The following is a description of a gene set: Human Gene Set: GSE39916_B_CELL_SPLEEN_VS_PLASMA_CELL_BONE_MARROW_DN Genes down-regulated in spleen B lymphocytes versus bone marrow plasma cells. from publication Benson MJ, Aijö T, Chang X, Gagnon J, Pape UJ, Anantharaman V, Aravind L, Pursiheimo JP, Oberdoerffer S, Liu XS, Lahesmaa R, Lähdesmäki H, Rao A (PMID 22991471) CD138+ B220- plasma cells were sorted from bone marrow and B220+ CD23+ mature follicular B cells were sorted from the spleens. Plasma cells were sorted from C57BL/6 mice 7 days after boosting with antigen, with mice first primed with an i.p. injection of KLH/IFA followed by boost at day 21 with KLH/PBS i.p. Mature B cells were sorted from antigen-naïve C57BL/6 mice. We compared expression profiles of plasma cells and mature B cells to identify differentially expressed transcripts. species: Homo sapiens, and this is the list of marker genes: SCN8A, TSPAN3, TPST2, SALL1, ITM2C, PLSCR1, RNASE4 (ribonuclease A family member 4), ABCB1, TRH, ORAI3, RBM47, ZDHHC2, HMGN3, ENPP1, ST3GAL6, BCL2A1, IL18RAP, FLOT1 (NCBI Gene Id 10211), RALGDS, CSF2RA, NR1D1, NRP1, ATXN1L, BAG3, MAPRE2, S100A6, PID1, OSBPL3, PARP16, CAMK2N2, MTHFS, EID2, GRN, RAPH1, GPM6B, SEMA7A, REPIN1, PTPN13, ID2, SP7, MEF2B, IFNAR2, PEAR1, S100A11, CD44, VMP1, ADORA2A, NUDT16L1, SLC26A11, KIF5C, ENDOD1, CDKN1A, NKG7, HACD3, GAA, CDK5R1, PVT1, TSPAN31 (tetraspanin 31), CHIC1, ALAD, CDC42EP3, TRAF1, IL7R, STX11, CTSW, EPSTI1 (epithelial stromal interaction 1), CEMIP2, PROS1, CIBAR1, ERN1, APP, NDNF, SRXN1, LGALSL, GPRIN3, CHSY1, S100A4, CAPSL, MICAL1, DNAJB2, FLYWCH2, PLXNC1, SYT11, MYADM, TEX9, GRAMD1B, EFHD2, TMEM65 (NCBI Gene Id 286052), SHLD1, PCNX4, TRIM35, CYSLTR2 (NCBI Gene Id 57105), ATP2B1, PTGER2, RNF157, TNFSF14 (TNF superfamily member 14), MATK, POU6F1, RAB39B, CDC25B, TRIP10, AHNAK, ITGB1, GPR68, CRMP1, GARIN3, GBP4, CAPN2, B3GNT5, PRKAR2A, ICOS, PRR13, ZC3H12D, CASP1, CXCR5, ARHGAP26, ZFPM1, CCDC126, CFAP418, PLAGL1, MAPK12, IL2RB (interleukin 2 receptor subunit beta), PCTP, SLC9A9, PDE8A, PCGF2, PRSS12, ADK, PLXNB1, FAM241B, CERS4, NRARP, IFT81, RORA, ST8SIA2, NLRP9, CCL5, CXCR3, KCNK6, SMPDL3B, CTNNA1, HIF1A, ASNS, ABHD14A, SPOCK2 (NCBI Gene Id 9806), TBRG1, TLR3, IFITM10, EDA, GPR155, KRTAP26-1, BAIAP3, TTLL12, TMT1A, TPI1, YBX3, TRPM6, RAB8B, AIG1, ERCC6L2, ZBTB42, MYO1F, TOX2, NT5E, ZCCHC3, KCNC2, TBX21, LANCL3, SURF1 (SURF1 cytochrome c oxidase assembly factor), GPANK1, ARHGAP5, IFNG, CST7, GCNT1, ATOSB, EPB41L5, TTC39C, DHDH, PPP3CC, SORL1, HIGD1C, PFN2, MAF, APOBEC3B, APOH, NCF4, LPXN, POGLUT3, GZMK, HES2, PDE2A, GLIS3, OSTF1, IER3, SMPDL3A, LAX1, GPR34, IL18R1, GSG1, JDP2